Given this list of marker genes MAP3K20, CSNK1E, PLK4, FOXO4, DKC1, CDK8, TAOK1, MAP3K14, CSNK1G3, here is a description of the gene set: Genes required for both proliferation and CTNNB1 activity in DLD-1 cell (colon cancer with APC deletions). studied in species Homo sapiens from publication Firestein R, Bass AJ, Kim SY, Dunn IF, Silver SJ, Guney I, Freed E, Ligon AH, Vena N, Ogino S, Chheda MG, Tamayo P, Finn S, Shrestha Y, Boehm JS, Jain S, Bojarski E, Mermel C, Barretina J, Chan JA, Baselga J, Tabernero J, Root DE, Fuchs CS, Loda M, Shivdasani RA, Meyerson M, Hahn WC (PMID 18794900) Human Gene Set: FIRESTEIN_CTNNB1_PATHWAY_AND_PROLIFERATION Aberrant activation of the canonical WNT/beta-catenin pathway occurs in almost all colorectal cancers and contributes to their growth, invasion and survival. Although dysregulated beta-catenin activity drives colon tumorigenesis, further genetic perturbations are required to elaborate full malignant transformation. To identify genes that both modulate beta-catenin activity and are essential for colon cancer cell proliferation, we conducted two loss-of-function screens in human colon cancer cells and compared genes identified in these screens with an analysis of copy number alterations in colon cancer specimens. One of these genes, CDK8, which encodes a member of the mediator complex, is located at 13q12.13, a region of recurrent copy number gain in a substantial fraction of colon cancers. Here we show that the suppression of CDK8 expression inhibits proliferation in colon cancer cells characterized by high levels of CDK8 and beta-catenin hyperactivity. CDK8 kinase activity was necessary for beta-catenin-driven transformation and for expression of several beta-catenin transcriptional targets. Together these observations suggest that therapeutic interventions targeting CDK8 may confer a clinical benefit in beta-catenin-driven malignancies.